Given this list of marker genes IPCEF1, HBZ, HBQ1, HBM, HBB, HBA1, HBA2, HBE1, HBD (NCBI Gene Id 3045), NGB, HBG1, HBG2, CYGB, MB, here is a description of the gene set: Binding to oxygen and delivering it to an acceptor molecule or a specific location. studied in species Homo sapiens Human Gene Set: GOMF_OXYGEN_CARRIER_ACTIVITY